Given this list of marker genes MDH1, BRAF, ME2, FH, PDHA1, ME1 (NCBI Gene Id 4199), PDK1, TP53 (tumor protein p53), GOT1, PDP2, here is a description of the gene set: TCA cycle in senescence Human Gene Set: WP_TCA_CYCLE_IN_SENESCENCE studied in species Homo sapiens